The following is a description of a gene set: Any process that activates or increases the activity of a cyclase. studied in species Mus musculus Mouse Gene Set: GOBP_POSITIVE_REGULATION_OF_CYCLASE_ACTIVITY, and this is the list of marker genes: Calca, Adcy7, Gnal, Cacna1c, Raf1, Calcr, Adcy1, Adcy2, Mapk3, Adora2b, Acr, Nf1, Adcy3, Orai1, Adcyap1, Lhcgr, Nos3, Stim1, Mapk14, Adcy4, Cacna1d, Drd1, Mapk8